The following is a description of a gene set: species: Homo sapiens The tapered base of the stereocilium adjacent to where it joins the hair cell body. This region contains a rootlet comprised of bundled actin filaments which spans the joint and stabilizes the stereocilium. Human Gene Set: GOCC_STEREOCILIUM_BASE, and this is the list of marker genes: PTPRQ, MYO7A, GRXCR2, PJVK, TPRN, RDX, TRIOBP